The following is a description of a gene set: Human Gene Set: GSE5589_LPS_VS_LPS_AND_IL10_STIM_MACROPHAGE_45MIN_DN from publication El Kasmi KC, Holst J, Coffre M, Mielke L, de Pauw A, Lhocine N, Smith AM, Rutschman R, Kaushal D, Shen Y, Suda T, Donnelly RP, Myers MG Jr, Alexander W, Vignali DA, Watowich SS, Ernst M, Hilton DJ, Murray PJ (PMID 17114459) Genes down-regulated in bone marrow-derived macrophage (45 min): LPS versus IL10 and LPS. IL-10 or IL-6 stimulation of control 129xC57BL/6 murine bone marrow derived macrophages in the presence of LPS. We used microarrays to detail the global programme of gene expression changes in response to IL-6 or IL-10 stimulation in the presence of lipopolysaccharide. BMDMs were isolated from control, IL-6-/-, and IL-10-/- mice on a 129XBL/6 mixed background mice and differentiated in the presence of CSF-1 for 6-7 days. Cells were scraped and plated in 6 well plates at 2x10e6/well. Cells were washed with complete DMEM and rested for 1-2 hr before stimulation with combinations of IL-10 (10 ng/ml), IL-6 (2 ng/ml) or LPS (100 ng/ml) for 45 min or 180 mins. Complete biological replicates were performed. studied in species Homo sapiens, and this is the list of marker genes: TPRG1L, NEGR1 (neuronal growth regulator 1), EXOC3L1, AATF, KAT14, SNX10, HCRTR2, NUAK1, LIPA, GNA12 (NCBI Gene Id 654140), DMKN (dermokine), RAB3B, ITGAV, GPSM3, TRNAU1AP, TENT2 (terminal nucleotidyltransferase 2), ANGPTL4, RAB29, SLC7A13, FAM222B, SLC3A2, ACO1, MED30, ADGRL2, UBALD1, MGST2, LEFTY2, GNGT2, TLE1, SPEN, TOMM7, PUM1, PLXNB2, TIAM2 (TIAM Rac1 associated GEF 2), SASH3, EXOSC5, NAT8L, BLVRA, CD82, SAMD4A, EPOR, ISX, KIAA0232, LRRC39, NATD1, ADPGK, MYLIP, KCNQ3, PRRC2A, OTOF, RDH10, CANT1, MCTS1, DGKZ, SLC41A1, ADGRE1, TRIM65, HNRNPL, WASF2, DNAJB14, GPCPD1, SPIC, REN (renin), MADD, ADRA2B, C19orf12 (chromosome 19 open reading frame 12), SLC27A1, CRYBB1, RIMS3, TRO, MARK2, SAYSD1, GZMM, ZKSCAN5 (zinc finger with KRAB and SCAN domains 5), UBE2G2, CFHR1, ANGPTL3, SHISA9, SLC26A6, GNB3, BHLHE40, ATP13A3, UGT2B17, RHBDL3, TALDO1 (transaldolase 1), PLIN2, REEP5, APOC1, ABHD15, CHTF8, ACAA1, KRT72, DYRK2, COA8, PPP1R7, SNX11 (NCBI Gene Id 29916), MARF1, PCSK4, TVP23A, MAPKAPK2, KLF13, MERTK, EIF4G3, CPT1A, ARHGAP39, SLCO2B1, RALY, SUSD3 (sushi domain containing 3), HEBP1, NLRP10, MAP3K8, ASB4, RAB39A, EXOC3L4, SLC39A1, KLF7, IRAK1, FSD1, ALKBH3, KHDRBS1, MEGF9, NEURL2, BOK, TMEM150B, CETN1, ITPK1, ASPA, BZW2, STARD5, SORT1, RANBP3, GPLD1, ABHD12, TXNRD2, ACAA2, ECH1, ABHD3, DMXL2, M6PR, HES2, MMD, HDAC5, PEX11A, DYNLT1, TMEM42, ECI1, SYNE2, QKI, ANAPC13, TAF1C, PAQR9, FRK, RUNX2, SPAG7 (NCBI Gene Id 9552), FAM53B, GPN3, CDKAL1, SYNE3, DNAH5, GGA1, VCAM1, MAFB, NXF3 (nuclear RNA export factor 3), NDUFV1, GPR4, ARHGAP32, PARL, SIRPB1, NR1H3, RNF5, BRD4, TEX264, EXTL1, SENP6, LPCAT3, CDC123, UBC, RAB5C, C11orf54, SREBF1, LPIN2, TMEM243, HADHB, MNT, AGPAT3, BMP5, CMPK1, TPRA1, HESX1, HPCAL1, RBM47, CASP8 (caspase 8), OLFML3, LIMA1, ANO3, TECPR2, BOD1L1, PRRG3, TREML4, ARFGAP1